Given this list of marker genes AFG2A, KCNA1, NEXMIF, SCN8A, DCX, TIMM50, KCNT2, STXBP1, GFM2, SCN1B, ARX, PLPBP, NUS1, GABRB3, ALDH7A1, ACTL6B, SLC32A1, CAPRIN1, NEUROD2, PHACTR1, MPDU1, KCNT1 (NCBI Gene Id 57582), PIGA, CLTC, ALG3, ALG2, NAXD, MGAT2 (alpha-1,6-mannosyl-glycoprotein 2-beta-N-acetylglucosaminyltransferase), DEPDC5, YWHAG (NCBI Gene Id 96443), NPRL3, AIMP2, ARV1, TRAPPC12, PPP3CA, GABRA2, HCFC1, DMXL2, TBC1D24, PARS2, CACNA1B, GAD1, SPTBN1, SLC35A2, SLC1A4, SLC38A3, HCN1, WWOX, KCNB1, SETBP1, TRIM8, GABRA5, SYNGAP1, NACC1, NEDD4L, AARS1, PAFAH1B1, PLCB1, PTS, NTRK2, PIGW, GCSH, TRAK1, MED17, FBXO28, GABRB2, EEF1A2, LONP1, ATN1, SZT2, DPAGT1, HID1, AP3B2, CTNNA2, SLC39A8, KCNA2 (potassium voltage-gated channel subfamily A member 2), CNPY3, ERMARD, ZNF526, PIGP, FZR1, COX4I1, GRIN1, KCNJ11, GRIN2B, CACNA1A, GLYCTK, SLC1A2, ATP6V0A1, WDR45, NPRL2, GRIN2D, CASK, NARS2, SLC25A22, ATP7A, DHDDS, IER3IP1, APC2, GUF1, RUSC2, PIGQ, PLAA, SYNJ1, CCDC88A, PDHA1, MT-TL1, IARS2, CACNA2D1, ATAD1, CUX2, ABCC8, GOLGA2, SLC13A5, ROGDI, CUL3, HMGCL, CAMSAP1, PNKP (polynucleotide kinase 3'-phosphatase), CACNA1E, ESAM, PACS2, PCDH12, CDKL5, SPTAN1, GNB1, CNKSR2, TBL1XR1, ASNS, OTUD7A, SCN3A, DOLK, EXOC8, FGF13, SLC12A5, PTPN23, GNAO1, ALG13 (ALG13 UDP-N-acetylglucosaminyltransferase subunit), NF1, DALRD3, ATP1A2, FOXG1, PI4K2A, GRM7, UFC1, TUBB2A, NECAP1, KCNC2, GABRB1, SCN2A, ATP6V1A, ALG14, NDUFAF8, UPB1, TGFB1, GABRG2, GNB5, FGF12, CYFIP2, SMC1A, ARFGEF2, EPM2A, SIK1, CELF2, UBA5, NHLRC1, GABBR2, CDK19, HIBCH, ATP1A3, DOCK7, ST3GAL3, KCNQ2, PPFIBP1, SCN1A, ASPA, ZNHIT3, PHGDH, SATB1, D2HGDH, MFF, MDH1, DNM1, UGDH, ARFGEF1, here is a description of the gene set: species: Homo sapiens Hypsarrhythmia is abnormal interictal high amplitude waves and a background of irregular spikes. There is continuous (during wakefulness), high-amplitude (>200 Hz), generalized polymorphic slowing with no organized background and multifocal spikes demonstrated by electroencephalography (EEG). Human Gene Set: HP_HYPSARRHYTHMIA Hypsarrhythmia